Given this list of marker genes NEK3, DPYSL5, SYT12, ESRP2, TPD52L1, TMT1A, NEBL, AGR2, CDS1, ISY1 (NCBI Gene Id 57461), KRT8, SULT2B1, ANKRD50, SLC38A1, ISOC1, AKR1C1, NUP210, MYO6, MMP7, UCP2 (uncoupling protein 2), RERG, SLC22A3, SPINT2, BLVRB, PDGFB, SFT2D3, TRPS1, ANK3 (ankyrin 3), BCAM, RAB26, MDK, SCNN1A, GSTT1, CYB5A, MAGEA2, NSUN7, CCN5, SSH3, FBP1, GDA, ARHGEF5, CYBA, CLDN4, GSE1, IL17RB, NPY1R (neuropeptide Y receptor Y1), MSI2, PLXDC2, ICA1, GRB7, TFAP2C, TSPAN8, LRRC37A4P, SYTL2, VAV3, LRRC4, ELF3, PRLR, LLGL2, ST3GAL5, SLC4A10, AQP3, ERBB3, KRT18, NHERF1, DPP4, SELENBP1, MLPH (NCBI Gene Id 79599), NUP210L, CRABP2, MSX2, RASL10A, TJP3, ANXA9, HOOK1, BDH1, MSI1, PRR15L, IFI30, MNX1, CMAHP, RHOB, ARHGEF16, OLFM2, MAN1A1, C4B, EPCAM, DSP, CD9, HGD, TPD52, BMP7, UBXN6, CLU, NR1H3, MAP7, AIF1L, MTARC1, B3GNT3, FOXA1, CCL15, RGCC, CDKN2A, KIAA0040, S100P, KRT19, OCLN, IRX5, SYT17, NAT1, GPR160, MAL2, BTBD8, JUP, GATA3, CDH1, PPL, MUC1, CLDN7, here is a description of the gene set: Human Gene Set: MODULE_180 Genes in the cancer module 180. species: Homo sapiens